The following is a description of a gene set: studied in species Mus musculus Mouse Gene Set: GOBP_CARBOHYDRATE_DERIVATIVE_BIOSYNTHETIC_PROCESS The chemical reactions and pathways resulting in the formation of carbohydrate derivative., and this is the list of marker genes: Fpgt, Mlec, St6gal2, Ccl21a, Pigu, Entpd1, B3gnt2, Npc1, B3galt1, Slc35d1 (solute carrier family 35 (UDP-glucuronic acid/UDP-N-acetylgalactosamine dual transporter), member D1), Gfpt2, Sord, B3gnt7, Ak1, Slc35c1, Nanp, Abca7, Ndufv3, Ak2 (adenylate kinase 2), Gcnt3, Nme2, Nus1, Gucy2d, Gucy1a1, Ndufc1, Gcnt2, Gfus, Edem3, Ugdh, Ampd2, B3galt6, B4galt7, Il4, Pdgfrb, Gxylt1, Xylt1, Csgalnact2, B4galt3, Ndst1, Cda, Lipc, Rft1, Pign, Xylb, mt-Atp6, Ccnd3, Hprt1, Serpina1b, Galnt6, Hs3st1, Nme7, Galnt11, Gk2, Itm2b, B4galnt1, Poglut2 (protein O-glucosyltransferase 2), Atp6-ps, Letmd1, Ndufa1, Aatf, Bmpr2, Alg8, Slc35b2, Aprt, Vcp, B3glct, Stat3, Pdgfb, Pate6, Atp5mc3, Alg10b, Large1, Fut4, Ust, Adsl, Adal, Man2a1, Fut2, Pgk1, Adcy5, Tyms, Galnt4, Adcy8, Ndufb6, Ndufa7, Rfk, Pgap2, Rrm2b, Galntl6, Ugcg, Ramp1, Cryl1, Has3, Tk1, Tet2, B4gat1, Ost4, Fcsk (NCBI Gene Id 68821), Ldhc, Ak9, Pmm2, Frey1, Eogt, Gnpnat1, C1galt1c1, Dpm3, Chst13, Fam20b, Gorasp1, Atp5pf, Parp1, Slc4a10, Mgat2, Dnajc30, Slc25a13, Dpagt1, Hs3st5, Gucy2f, B3galt4, Pomgnt2, Galnt16, Smpd3, Ndufs5, Gnpda1, Antkmt, Mgat5, Hs3st2, Slc2a10, Aldoa, Mppe1, Pid1, Ndufs3, Gmps, Alg6, Gmppa, Necab1, Tpi1, Adcy10, Hs3st3b1, Pigt, Chst11, Galnt1, Acot8, Derl3, Umps, B4galt6, Dolpp1, Gxylt2, Adcy7, B3galnt2, St6galnac5, Atp5f1d, Myc, Pcx, Ccl19, Tm9sf2, Tmtc1, mt-Nd6, Ndufs6, Uprt, Lipa, Tcf7l2, Stt3a (STT3, subunit of the oligosaccharyltransferase complex, homolog A (S. cerevisiae)), Nme1, St8sia2, Gucy2e (NCBI Gene Id 503686), Trem2, Tmem106a, Slc25a12, Ndufb7, Nme3, Ndufb10, Gucy2c, Gapdh, Gfpt1, B3gat2, Pigx (NCBI Gene Id 72084), Rxylt1, Atp5f1e, A3galt2, Gmppb, Mdh2, Nans, Hs6st3, 4930568D16Rik, Atp5f1c, Dpm2, Chst3 (carbohydrate sulfotransferase 3), Prps2, St6galnac1, Atp5mg, Ces2a, Tkt, Eno1b, Nme5, Gal3st2, Tmtc3, Akr1a1, Ak3, Mgat4a, Adcy4, Tyw1, Slc2a1, B3gnt8, Tnip1, Pgap3, Uck2, St8sia3, Dtymk, Ndufa5, Serpina1a, Slc39a8, Stoml2, Ldhd, Galnt17, Cog7, Amdhd2, B3galt5, Dse, Mgat4c, A4galt, Atpsckmt, Fut11, St8sia1, Abo, Sec1, Ndufa3, Mdh1, Uck1, B3gat3, Fkrp, Gykl1, Atp5mc2, Fut9, B3galt2, St6gal1, Ndst3, Gcnt4, Stt3b, Atp5po (ATP synthase peripheral stalk subunit OSCP), Pomgnt1, Mgat4d, Map2k1, Galnt10, B3gnt3, Sdhb, St3gal4, Trip11, Galnt14, Chst7, Plcb1, St3gal2, Alg12, Pigf, Angpt1, Galntl5, Ndufb4, Necab2, B4galt1, Sdha, Nagpa, Ndufa10, Gal3st4, Impdh2, Galnt9, Fut8, Ctps1, Sphk2, Ctnnb1, Mgat3, Ext2, Tgfb1, Prps1l3, B3gnt5, Bmpr1b, Prps1, Slc25a10, Nudt2, Ndufb2, Atp5pd, Has2, Pomk, Hk1, Nppa, B4galnt4, Slc51b, Krtcap2, Pigc, Crppa, Jak3, B4galt2, St6galnac4, Rpn1, Tyw3, Galnt12, Sdhd, Ndufs1, Alg2, Hs3st4, Sdhc, Shmt2 (serine hydroxymethyltransferase 2 (mitochondrial)), Chsy3, Nppb, Hs3st3a1, Xxylt1, St8sia5, Pigb, Gne, St3gal1, Man1c1, Ppara, Dmac2l, Vangl2, Extl3 (NCBI Gene Id 78404), B3gnt9, Uap1 (UDP-N-acetylglucosamine pyrophosphorylase 1), Dnph1 (NCBI Gene Id 98052), Dut, Sccpdh, Hyal1, Adss2, Pigs, Cytl1 (NCBI Gene Id 231162), B4galt5 (UDP-Gal:betaGlcNAc beta 1,4-galactosyltransferase, polypeptide 5), Chst10, Chpf2, Pawr (NCBI Gene Id 76427), Mpi, St6galnac3, Mgat1, St6galnac2, Man1b1, Golga2, Atg5lrt, Ndufv1, Pigz, mt-Nd3, Cog3, Pnp, Man1a, Il1b, Ndufa12, Adcy9, Pomt1, mt-Nd1, Man2a2, Tmem260, Ampd1, Ube2j1 (NCBI Gene Id 80530), B4galnt3, Galnt7, Galnt5, Ndufs7 (NADH:ubiquinone oxidoreductase core subunit S7), Chst12, Lmf1, Soat1, Pigm, Pigw, Pigv, Dck, Ndufs4, Pgm2 (phosphoglucomutase 2), Mgat4e, Atp5pb, Slc30a5, Hs6st2 (NCBI Gene Id 50786), Mgat4f, Alg11, Trak2 (trafficking protein, kinesin binding 2), Acan, Il15, Uqcc3, Galnt3, mt-Atp8, Pygl, Ada, B3galnt1, Papss1, Ggta1, Pfas, Prkn, Trmt12 (tRNA methyltransferase 12), Gucy1b1, Pigh, C1galt1, Ugt8a, Gpaa1, Large2, Xylt2, Abca2, Dhodh, mt-Nd4, mt-Nd2, Rrm1, Alg1, Ptger4, Hs2st1, B4galnt2, Oga, Cad, Pofut2 (NCBI Gene Id 80294), Dad1, Ndufs2, Ndufa8, Ddost, Cmpk2, Ogt, Nme4, Acer2, Gata1, Ndufb9, Mogs, Bcl2, B4galt4, Cwh43, St8sia4, Uggt1, Ndufb8, Gcnt7, Ndst2, Ndufc2, Cltc, Ndufa13 (NCBI Gene Id 67184), Guk1, Uap1l1, Adcy2 (NCBI Gene Id 238696), St3gal6, Galnt15, Cmpk1, Gcnt1, Atp7a, Gucy2g, Slc35c2, Paics, Adcy1, Pgam1, Uckl1, Pigk, Pth2, Gal3st2c, A4gnt, Ugp2, Cox11, Tmtc4, Poglut3, Ndufa11, Tmem258 (NCBI Gene Id 69038), Upp1 (uridine phosphorylase 1), Adss1 (NCBI Gene Id 11565), Dhfr, Chp1, Cant1, Dguok, Shmt1, Hnf1a, Nfkb1, Dpm1, Gmds, Extl1, Slc10a7, Igf1, Adk, St3gal5, Atp4b, Tmem59, Uxs1, Atp5me, Srd5a3, Pgm3, Ago2, Nme6, Fam3a, Atp5if1, Chst5, Ndufb1, Tet1, Impdh2-ps, Ndufa6, Man1a2, Chst14, Hbegf, Piga, Gnpda2, Ndufb3, Itm2c, Egf, Alg9, Ap2a1, Ak4, St8sia6 (NCBI Gene Id 99126), Ndufa9, Fut1, Bcl2l1, Magt1, Gk5 (NCBI Gene Id 320574), B3gnt4, 6430550D23Rik, B3gat1, Tbpl1, Prps1l1, Pigg, Ncstn, Il33, Ppat, Alg14, Ndst4, Ndufv2, B3galt9, Pigq, Pyurf, Mgat4b, Papss2, Pgap4, Csgalnact1, Slc2a4, Hexa, Atic, Prpsap1, Phlda1, Gal3st3, Nppc, Adcy3, Fut7, Ostc, Ndufa2, Aqp11, Pmm1, Dolk, Pck1, Prpsap2, Ndufb5, Galnt13, Psen1 (presenilin 1), Chsy1, Impdh1, Has1, Ep300, Uggt2, Hs6st1, Npr2, Ndufab1, Upp2, Adcy6, Glce, Gbgt1, Golph3, Chpf, Cmas, Galnt18, Fut10, Hs3st6, Lcmt2, Mtap, Pofut1 (protein O-fucosyltransferase 1, NCBI Gene Id 140484), Vegfb, Tyw5, Ndufb11, Pigyl, Chst9, Qng1, Gart, Fktn, Pomt2, Rrm2, Pigp, mt-Nd4l, Mgat5b, Alg13, Gmpr2, Alg5, Itm2a, Mthfd1, Ccdc134, Ext1, Tmem165, B3gnt6, Entpd5, Slc35d2, Npr1, Dctd, Galnt2, Atp5f1b, Insr, St6galnac6, Slc35a1, Gal3st1, G6pd2, Gk, Arfgef1, Tmsb4x, Mustn1, St3gal3, Poglut1, Ctps2, Dhdds, Gmpr, Atp6v1a, Atp5mf, Atp5f1a, Pgap1, Alg3, Dpy19l1, Chst1, Eno1, Gpd1, Abcc5, Ampd3, Bace2, Pxylp1, Foxl1, Necab3, Nt5e (NCBI Gene Id 74242), Fa2h, Pigo, Dcxr, Tusc3, Pigl, Trex1, Fuom, Tet3 (NCBI Gene Id 320786), G6pdx, Dpy19l3, Rpn2, Atp5mc1, Plod3, Chst8, mt-Nd5, Ndufs8, Ccr7, Tmtc2